The following is a description of a gene set: studied in species Homo sapiens Human Gene Set: GOBP_SYNAPSE_ASSEMBLY The aggregation, arrangement and bonding together of a set of components to form a synapse. This process ends when the synapse is mature (functional)., and this is the list of marker genes: RYK, ADGRL3, PCDHB14, RAP2A, PLXND1, ADNP, DNER, ABI3, SIX1, GABRA1, GPM6A, GABRG2, PTEN, LRFN1, AMIGO3, NCKIPSD, NTRK2, CTNNB1, THBS2, SYNDIG1, LRRTM1, PRKCA, LRFN4, CDH1, PPP1R9B, NTNG2, ELFN1, ADGRB3, CHRNB2, GABRE, MECP2, SEMA4C, GABRA3, NPAS4, SIX4, PCDHB13, LRFN3, C1QL3, LIN7B, CRTAC1, GPHN, PDLIM5, PLXNA1, WNT3A (Wnt family member 3A), LRRC24, RTN4 (NCBI Gene Id 57142), HTR4, CAPRIN1, FGFR1 (fibroblast growth factor receptor 1), PCDHB10, FBXO45, LRRC4, TPBG, CDH2, ZDHHC8, GABRG3, CARMIL3, ZDHHC2 (zinc finger DHHC-type palmitoyltransferase 2), GNPAT, SDK1, DKK1, SDK2, GABRA6, EPHB3, GABRA2, DRD1, PDZD11, CSMD2, SLITRK4, GRIA1, PUM2, PLXNB1, LIN7A, CRMP1, ABL1, EEF2K, SEMA4A, GABRB2, CRKL, NTN1, PCLO, DRD2, NLGN2, GABRG1, NPTX1 (neuronal pentraxin 1), PCDHB11, CBLN4, SPTBN2 (NCBI Gene Id 6712), NEGR1, PLXNA4, SRGAP2C, RTN4R, CC2D1A, FZD5, APP, CUX2, SHANK3, ARHGEF15, GPC4, ZDHHC12, STAU2, CLSTN3, ADD2, SRPX2, MYCBP2, SETD5, CDK5, NEDD8, PRICKLE1, EPHB2, ARHGAP12 (Rho GTPase activating protein 12), FZD1, ARHGEF9, TLR2, GNA13, GJA10 (gap junction protein alpha 10), NLGN4Y, MARK1, ASIC1, RELN, RHOG (NCBI Gene Id 391), PCDHB5, LRFN5, LRTM2, ADGRF1, DBNL, NTRK1, IQSEC2, SLITRK5, LZTS1, DLG5, CYFIP2, LRRN1 (NCBI Gene Id 91907), GABRA5, IL1RAP, PTPRD, LRRC4B, NRXN1, VPS35, LGI2, NUMBL, MAPT, DOCK4, ST8SIA2, FLRT2, SIGMAR1, DVL1, NLGN1, VLDLR, WNT5A, NEURL1, GHRL, SLITRK1, FLRT1, LRRTM2, VSIG10, S1PR2, RAB17, LATS1, UBE3B, EFNA5, EIF4G1, PCDHB3, CRK (NCBI Gene Id 1398), LRRN3, NECTIN3, ADGRB2, ARF6 (ADP ribosylation factor 6), EPHB1, ARHGAP33, CRIPT, PTK2B, FGF13, PCDHB9, COLQ, TRIM47, LRP4, PLXNB2, RAC3, NLGN3, LRIT3, SLITRK2, PTPRS, LIN7C, MAP1B, CBLN2, GPRASP3, SLITRK6 (SLIT and NTRK like family member 6), BSN, CBLN1, LINGO2, OXT, WNT7A, AMIGO2, MDGA1, PCDHB2, IL1RAPL2, PLXNA2, DNM3, SLC25A46, PLXNB3, AMIGO1, SEMA4D, C1QL2, BDNF, NAE1, DSCAM, ICAM5, SRGAP2, RAC1, NECTIN1, PTPN1, ACHE, PCDHB4, PCDHB6, CLSTN1, POU4F1, GRM6, CLSTN2, SNCA, ADGRL2, SLC12A5, KIRREL3, SENP1, IL1RAPL1, RAB29, KCNJ8, CHD4, CASKIN1, UBE2M, AGRN, ARMCX5-GPRASP2, NPTN, LINGO4, HAPLN4, ERBB4, ELMO1, GRID2, ADGRB1, PCDH17, SLIT1, ROBO2, SPOCK2, FLRT3 (fibronectin leucine rich transmembrane protein 3), MEF2C, ASIC2, GABRA4, LARGE1, PLXNA3, SRGAP2B, EPHA7, NRG3, LRRTM3 (NCBI Gene Id 347731), EFNB2, FARP1, OGT, PCDHB16, NRXN2 (neurexin 2), MUSK, DOCK1 (dedicator of cytokinesis 1), DOCK10, GABRB3, VSTM5, NRCAM, PLXNC1, NLGN4X, NTRK3, IGSF11, PTPN13, CNTN5, SHANK2, MIR431, GHSR (growth hormone secretagogue receptor), GAP43, SLITRK3, LHFPL4